Given this list of marker genes TWIST1, CREBBP, FGFR2, RAB23, C2CD3, HYLS1, ACTB, TBX5, CANT1, EP300, KIAA0753, FGFR3, KIF7, NIPBL, NEK1, here is a description of the gene set: Partial/complete duplication of one or more phalanx of toe. Duplication of phalanx of toe Human Gene Set: HP_DUPLICATION_OF_PHALANX_OF_TOE species: Homo sapiens